Given this list of marker genes ELOB, EPAS1, PSMB7, PSMC3, UBA52, PSMC2, PSMC5, ADRM1, CITED2, PSMB4, PSMA3, EGLN1, HIF3A, SEM1, ELOC, PSMB6, RBX1, PSMC6, PSMD11, UBE2D3, AJUBA, PSMD12, PSMD1, CA9, EGLN3, PSMA7, CUL2, PSMA5, PSMD7, EP300, PSMA2, PSMD6, PSMC4, ARNT, PSMA4, PSMD13, VEGFA, PSMD3, PSMB3, UBB, PSMD14, LIMD1, UBE2D1, HIF1A, PSMA1, HIF1AN, UBE2D2, HIGD1A, PSMA6 (NCBI Gene Id 87553), PSMD8, WTIP, VHL, EGLN2, UBC, PSMB2, PSMB5, EPO, PSMD2, CREBBP, RPS27A, PSMB1, PSMC1, here is a description of the gene set: Reactome Pathway: Cellular response to hypoxia part of: Cellular responses to stress species: Homo sapiens Oxygen plays a central role in the functioning of human cells: it is both essential for normal metabolism and toxic. Here we have annotated one aspect of cellular responses to oxygen, the role of hypoxia-inducible factor in regulating cellular transcriptional responses to changes in oxygen availability.<p>In the presence of oxygen members of the transcription factor family HIF-alpha, comprising HIF1A, HIF2A (EPAS1), and HIF3A, are hydroxylated on proline residues by PHD1 (EGLN2), PHD2 (EGLN1), and PHD3 (EGLN3) and on asparagine residues by HIF1AN (FIH). Both types of reaction require molecular oxygen as a substrate and it is probable that at least some HIF-alpha molecules carry both hydroxylated asparagine and hydroxylated proline.<br>Hydroxylated asparagine interferes with the ability of HIF-alpha to interact with p300 and CBP while hydroxylated proline facilitates the interaction of HIF-alpha with the E3 ubiquitin ligase VHL, causing ubiquitination and proteolysis of HIF-alpha. Hypoxia inhibits both types of hydroxylation, resulting in the stabilization of HIF-alpha, which then enters the nucleus, binds HIF-beta, and recruits p300 and CBP to activate target genes such as EPO and VEGF.